The following is a description of a gene set: from publication Chen Y, Wang X (PMID 31504780) Genes predicted to be targets of miRBase v22 microRNA hsa-miR-381-5p in miRDB v6.0 with MirTarget v4 prediction scores > 80 (high confidence targets). Human Gene Set: MIR381_5P species: Homo sapiens, and this is the list of marker genes: DOCK10, DDN, CTPS1, RALGAPB, MTCH1, CAP2, RASSF3